Given this list of marker genes Snx27, Dlg4, Grip2, Zdhhc2, Ssh1, Rapsn, Apoe, here is a description of the gene set: studied in species Mus musculus Mouse Gene Set: GOBP_REGULATION_OF_POSTSYNAPTIC_MEMBRANE_ORGANIZATION Any process that modulates the frequency, rate or extent of postsynaptic membrane organization.